The following is a description of a gene set: Protein-losing enteropathy Human Gene Set: HP_PROTEIN_LOSING_ENTEROPATHY studied in species Homo sapiens Abnormal loss of protein from the digestive tract related to excessive leakage of plasma proteins into the lumen of the gastrointestinal tract., and this is the list of marker genes: ALG6, CARD8, PLVAP, PET117, DGAT1, ALG1, BMPR1A, ALG8, PIK3C2A, MPI, CCBE1, STAT1, COG8, ADAMTS3, PKHD1, BLNK, PTEN, CD55, DZIP1L, FOCAD